The following is a description of a gene set: from publication Yevshin I, Sharipov R, Kolmykov S, Kondrakhin Y, Kolpakov F (PMID 30445619) Human Gene Set: SETD1A_TARGET_GENES Genes containing one or more binding sites for (SETD1A) in their promoter regions (TSS -1000,+100 bp) as identified by GTRD version 20.06 ChIP-seq harmonization. studied in species Homo sapiens, and this is the list of marker genes: TTLL5, FNBP1, FANCM, CIDECP1 (CIDEC pseudogene 1), CUL9, SEPTIN7, ZNF148, SLC25A26, COPS7B, SNHG29, CDK1, NDUFAF1, GMFB, NDUFA9, NUMB, YY1AP1, NOP16, RBM12B-DT (RBM12B divergent transcript), SRPRA, TACO1, USP18, TCEANC2, JRK, PSMA3-AS1, C19orf48P, TOMM22 (NCBI Gene Id 56993), MRPS16, TIMM10, RNF213-AS1, MYBL1, BTRC, C9orf43, HEATR6, CNOT6, CIAO2A, TPR, AKAP3, SLC3A2, TOMM22-DT, TUT1, TMEM256, NUCB1-AS1, UQCC3, PLEKHA8, PPP1R8, RPL3, TMEM237, CMTR2, SGO1-AS1, FBXW7, NDUFS4, UCKL1, SRSF10, PRDM10-DT, ATF6-DT, ESPL1, RPL29, MRPS30-DT, KLHDC3, FAM187A, SEPTIN7P13, CBFB, MICU2, TMEM167B-DT, ZNF596, KPNA6, ATF7-NPFF, LARS1, NECAP1, CPD, NOM1, TENT5A, DNAL1, GTPBP10, NUDT9, SLMAP, PCYT1A (NCBI Gene Id 5130), RPL30, SH3BP5L, ZNF524, SSBP1, LACTB, ZNF225-AS1, TCERG1, ESYT1, FOXRED1, TMEM9B, PATL1-DT, TAF5, FANCD2, PTCD2, CCDC59, ENSG00000253986, TMEM59, ZFAT, RLF, H2AC5P, TIAL1, HMBS, TMCC2 (transmembrane and coiled-coil domain family 2), COA6, RMDN1, SDHB (succinate dehydrogenase complex iron sulfur subunit B), PEX19, SBF2, DPH1, COX7A2, YARS2, TMA16, OXCT1-AS1, TSPAN31, GTF2IP20, CCT7, IRF9, PNN, DUS3L, STRAP, KMT5B, CTR9, GBF1 (golgi brefeldin A resistant guanine nucleotide exchange factor 1), KIAA0753, ZBTB40, PPP4R3B-DT, TCEA1, ABHD12 (abhydrolase domain containing 12, lysophospholipase), ALG12, TPRKB, STX18, SART3, IMP3, UBE3B, COMMD1, SLC25A37, VPS13B, PCLAF, FAU, C2orf42, SEC23B, AP1AR-DT, SAP30BP, PPP1R37, NUPR2P1, LINC01881, EID3, PES1, SH2B1, MED26, ARHGAP1, LINC01089, PAXBP1-AS1, NAV2, SNRPB, RPS27A, CFAP418, ZNF383, C7orf50, NUDCD1, SYS1-DBNDD2, STAMBP, ZNF501 (NCBI Gene Id 7602), CSTF3-DT, HADHB, KIF18B-DT, RABGGTB, MRPL21, RALGAPA1, SNRPC, BUD31, MIR638 (NCBI Gene Id 693223), SRRD, KLHL7, COQ7, NUDC, NUP85, EMC7, LEMD2, USP15, MTERF4, DHODH, DHRS1, MCM8, ZNF341-AS1, BAD, ZNF787 (NCBI Gene Id 126208), RPS15, HARBI1, GTF2IP13, STX18-AS1, FAM177A1, BSCL2, TRMT1, ERVK3-1, DRG2, DNM2, SYS1, MRTFA, KIF18B, CSNK2A1, ZNF83, UBL3, COMMD3, RPS13, CISH, ANAPC5, TOE1, GPS1 (NCBI Gene Id 2873), DDRGK1, ANKRD54, MED18, CEP120, PPP1R12C, MRPS15, ZNF585B, DHX16, RSL24D1, FDPS, WARS2-AS1, TIPIN, DYNC1I2, SF3A3, BSDC1, ENPP4, SUCLG1, TPX2, GTF2H1, ANKRD40, ANKMY1, GRWD1, XRCC5 (NCBI Gene Id 7520), DERL2 (derlin 2), ZZZ3, MKLN1-AS, GOLGA3, HEATR6-DT, SLC25A44 (solute carrier family 25 member 44), ZNF384, LETMD1, MTCH1, RPS12, ANKRD17-DT, SCRN3, NSA2, NAGK, NDUFA7 (NADH:ubiquinone oxidoreductase subunit A7), PYCR3, KEL, CDC42BPA, NELFA, ZNF25-DT, TOM1L2 (target of myb1 like 2 membrane trafficking protein), USP14, FBXL18, ITFG2, RPL18, TRAK2, R3HCC1, MRPS31P5, RFNG, CTNNBL1, MIR5091, ITGB3BP, RERE, GGA1, RAB21, ZNF585A, ARL8B, LAS1L, HMGXB4, RPL27A, VGF, MIR6790, ATG13, OGFOD3, HASPIN, NUP133-DT, DAXX, PAFAH2, ZW10, SLC66A2, HACD3, GID8, SOX2-OT, EIF1AD, AMBRA1, BOD1, ESF1, NCDN, DSTYK, MRPS30, RTTN, TTC32, CCND3, ISY1-RAB43, PPP3CB, THOC1, CD101-AS1 (CD101 antisense RNA 1), PSKH1, SLC25A11, CYB5R4, WDR37, U2SURP, C11orf58, SNF8, PTK2B, SLC25A28, CCDC115, MRPL35, SVIL-AS1, CDK5, WDR70, KIF15, NAPG, SLC4A1AP, ZNF414, ANKHD1-EIF4EBP3, BORCS8-MEF2B, URM1, TARS1-DT, MARCHF2, STAG3L5P, PHB1, ENSG00000260592, ERGIC2, ARPC4, LTN1, MRPL39, SENP3, MAPKBP1, MPV17, REXO1, UTP15, METTL9, PSMC3, LAMTOR5, SPAG9, DIDO1, COMMD9, TBCB, CRYZL1, PCBP1-AS1, YTHDF2, MICB, SEPTIN7-DT, SKA3, ATP5F1A, ZNF598, DNAJB12, MCRS1, MRFAP1, WDR43, EXOSC6, PYM1, ALG9, MKLN1, SETD1B, ATP6V0D1-DT, LINC00656, NUBPL-DT, ALG5, ABT1, PARP2, CLASRP, ZNF646, ZNF668, SYNJ1, TMEM230, TSN, NMT1, PHF8, ARMT1, KLC4, PUS3, RN7SL75P, SNORD49B, GTF3C3, ATAD3A, ZNF131, ZNF565, KCTD10, RNF167, SLC35A5, SNRPF-DT, MRPL22, UBAP2, DCP1B, HEXIM1, KRT8P12, EXOSC5, MAP3K11, SLC25A32, HSPA13, AMDHD2, GPR108, ATXN7L2, SEPTIN7P2, LBH, ZC2HC1C, MPDU1, CDKL3, ZFX-AS1, WASF1, RPL22, EEF1B2, PPP2R3B, STAP2, SMIM14, MAF1, TECPR2, AAR2, MRPS33, SLX4IP, NDUFAF8, EFCAB7, NDUFS6, PGBD4, VCPIP1, C19orf47 (NCBI Gene Id 126526), RSAD1, LSM5, CLCN3, SLC35B1, HADHA, LINC02288, SMPD4, FAM234A, PMS2P3 (NCBI Gene Id 5387), PPP2R3C, MAZ, CA1, SNORD15A, DPCD, DHX30, LARS2, UNC50, GPR137, CRYZ, RMND1, ARID4A, ACTMAP (NCBI Gene Id 284325), CENPM, POLL, GAR1, PMEL, DDB2, SNRNP27, CLP1, MTMR9, HAVCR2, FAM98B, SMAD6, VPS13B-DT, NXT2, CRACD, DCP1A, NOP9, ZC3H13, SUV39H1, MRPL49, ANGEL2, GRIPAP1, SMG7, RPTOR, MZT2B, RPS3, ADPRS, BORCS8, ATP13A4, ZNF350, GFOD1, SMARCA5-AS1, RRP1B, IRAG1-AS1, COPS4, NOC2L, PSMD7-DT, CCDC18, PIN4, DRC3, SHKBP1, RBSN, CDC40, ENSG00000268129, FAM228B, LIPE-AS1, YTHDC1, ANXA2R, RNU7-27P, FUZ, LAMP1, COG4, PTGES2-AS1, RPN1, ANKHD1, KDM1A, PIGK, PATL1, NUP133, PCBP1, CCT8, PDAP1 (PDGFA associated protein 1), KLHDC10, C1D, ASB16-AS1, ITGAE, HIBADH (3-hydroxyisobutyrate dehydrogenase), DESI2, LMNB2, LRIG1, COA8, SNRPF, SDCBP2-AS1, PDE6D, CCDC97, SUPT4H1, TNK2-AS1, MED7, LMNB1-DT, ZNF586, RBBP5, TTBK1, FIZ1 (FLT3 interacting zinc finger 1), JPX, CDC27, BLOC1S6, CACTIN, GSTCD, NUCKS1, SCAMP1-AS1, GBA1, LONP1, THUMPD1, MIR4512, PNO1, MCMBP (minichromosome maintenance complex binding protein), RBM26-AS1 (RBM26 antisense RNA 1), TRMT6, INO80B-WBP1, MEA1, VPS33A, SUPT5H, MIR3124, BRWD3, UBE2I, CHMP4B, AK2, DNAJA2-DT, LIX1L-AS1 (NCBI Gene Id 105371260), CREB3L4, RPS7, ST13, SNRPA1, ARMC1, PUF60, ARHGEF7, RAB5B, MANBAL, RTF1, CPSF7, MRPL36, CHASERR, DCUN1D3, KATNA1, SF1, NFXL1, CDK13, ENSG00000282936, PABIR1, DENR, E2F4, TTF2, TOR1A (torsin family 1 member A), TRIM56, DCAKD, CAMTA1, GCN1, DLGAP4, KNL1, HAX1, FAM149B1, NDUFS1, LARP4, EEF1E1-BLOC1S5, TRIP4, HEXD, BLOC1S1, CCRL2, MRPL1, VRK1, CNOT7, ZBTB43, SBNO1-AS1, ABCB9, CHCHD2P1, RNA5SP146, CDHR3, PI4KB, POMP, SPTLC1 (serine palmitoyltransferase long chain base subunit 1), DTD1 (NCBI Gene Id 92675), AREL1, CDC14A, MFAP3L, ERCC1, GTF2IP12, TLN2, ANKRA2, CDK5RAP1, CYB5B, USF3, ODR4, TMEM183A, TMEM256-PLSCR3, CAMTA1-DT, ARID3B, MDH1, MT-RNR1, MDN1, SLC25A53, GAR1-DT, ERP44 (NCBI Gene Id 23071), SMIM14-DT, EIF4A1, PCBP2, CDC73, EEF1E1, ALG10, NUP205, PPP4R3A, E2F6, MED23, TARS1, CASC3, LRPPRC, ARHGAP11B-DT, MAP3K7, MTOR, LARP7, DZANK1, MRPL16, AP1AR, CHCHD5, GOT1, TTC23, ENSG00000275740, TIA1, RFX1, SIPA1L3, HSF2BP, OBI1, DOHH, RN7SKP114, IZUMO1, NUDCD3, ARPC4-TTLL3, MED9, NDUFC2-KCTD14, FCF1, SIRT2 (NCBI Gene Id 22933), ZSWIM3, ENDOV, SNX1, ANKRD13A, LRRC41, C10orf143, KIAA1143, POLR2J4, WDR76, WDR89, MPPE1, RPL17, TARDBP, SPHK2, MRPL44, DPH3 (diphthamide biosynthesis 3), ARL6IP5, MAPK14, HCG14, TMEM38A, POLR1G, ZNF408, NUP93-DT, CDCA5, POLR3D, TRIP10, EMG1, SBNO1, SNHG31, IDH3B, ARL2BP, MED27, COQ7-DT, NBAS, VPS37A, ATG7, ANKRD17, RPIA, GTF2IRD1P1, PEX14 (NCBI Gene Id 5195), SEC13, LTO1, ITK, SCAMP1 (secretory carrier membrane protein 1), ZNF267 (zinc finger protein 267), DEPDC5, HDAC6, SREK1IP1, RPS8, RPLP2, MED31, ARL5A, CLUAP1, BRPF1, MIR4521, PKNOX1, CCR5AS, SNORA13 (small nucleolar RNA, H/ACA box 13), ATXN1L, ZNF160, RABEP2, ERG28, ATG9A, CEP350, OTUB1, TAFA2, NCOA5, EEFSEC, SRSF3 (serine and arginine rich splicing factor 3), NLGN2, KARS1, RBM26, LINC01932 (long intergenic non-protein coding RNA 1932), DHX35-DT, TIMM9, CPB2-AS1, BANF1, SNORD101, DDX19A-DT, SLC15A4, INVS, MAPKAPK5, SRFBP1, BCL6, TMEM222, TAF8, COPS8, CDC123, UQCRC2, POLR2I, PAK1, UQCRH, FAAP100, CHCHD2, ETFBKMT, AP1G1 (NCBI Gene Id 164), ENSG00000261335, CENPU, RFXANK, SP7, YME1L1, PIGB, TRDMT1, SURF1, FAM133B, SPAG4, ITSN1, ARHGAP19, ACOX3, WEE2-AS1, SLC7A1, FEM1A, TTC32-DT, CCDC12 (coiled-coil domain containing 12), NFKBIB, SZRD1, ADD2, XPNPEP3, RTN4IP1, BNIP2, VPS50, NOP58, CDKAL1, SRCAP, PNPLA4, MTF2, RPL17-C18orf32, SCAF4, EXOSC8, DCTN6-DT, NDUFC1, SF3B6, IL23A, RFX5, ICAM5, NUBP1, MAD2L1BP, ZDHHC12, LBHD1, NCBP2AS2 (NCBP2 antisense 2 (head to head)), SLC18B1, H4C8, ZC3H10, SPRED2, NCAPD2, SLC39A7, GABPA, C2orf49, OGFOD2, AP5M1, TFAP2A, RAB2B, TSPAN4, UTP3, RBM12B, C2orf49-DT, HS1BP3, AP3B1, KMT2A, FAM114A2 (family with sequence similarity 114 member A2), NIPA2, NDUFAB1, PRKRIP1, RAD51AP2, TIPRL, RPS10, TBCCD1, TRUB2, RPL7L1, CBR4, MIR4453HG, NFE2, IDH3B-DT, EPCIP-AS1 (NCBI Gene Id 54067), ATP8B1-AS1, ZNF510, SLC39A3, CEP162, BUD13-DT, CTSB, PAXBP1, VIRMA-DT, ZNF724, PLD3, WDPCP, EXOC5, DHPS, EWSR1, SMYD3, GUCD1, C9orf72, GOT1-DT, ALAD (NCBI Gene Id 210), NUP43, PRANCR, ALG1 (ALG1 chitobiosyldiphosphodolichol beta-mannosyltransferase), MIR320A (microRNA 320a), LAMTOR5-AS1, DUS2, CCDC174, VAMP3, RECQL5, UBE2B, BECN1, NLK, COPS8-DT, NDUFS7, CCT5, ANKRD18CP, POLR3A, KIAA1586, KBTBD7, MAP4K2, STRIP1, TM2D1, GANC, YJU2 (YJU2 splicing factor homolog), SF1-DT, NUBPL, MRPS28, HEATR1, NUP107, MRPL57, NUDT2, ATF6, RFX5-AS1, GTF2F1, ANKHD1-DT, WDR83OS, TMEM167A, ZNF451, INO80, IRAK4, LINS1, CLHC1, KDM5C, DNAJA2, TOX4, SNAPC2, EPB41L4A-AS1, SNRPG, FRG1, SSU72, CNPY2-AS1, MLST8, INO80B, ZCCHC7, UTP11, RBM28, ZNF718, C8orf33, TADA3, GGNBP2, CNOT2, CXXC1, QRSL1, RPL24, GPBP1L1 (NCBI Gene Id 60313), EIF2S3, MASTL, HPS4, TMEM198B (transmembrane protein 198B (pseudogene)), KIAA2013, SUPV3L1, TMEM39A, NUP54, MIR130AHG, CETN4P, ZNF564, KAT5, PSCA, TXNRD2, PRORP, ZNHIT6, C1orf159, KLHL22, ZGRF1, DHX32, AKAP8L, MICOS13, POLE3, MRPL2, ALG10B, CNOT1, TMEM242-DT, MFAP3, AQR, STRADB, PNPT1, ZNF736, HMOX1, HDAC1, WDR75, SLC30A6-DT, DARS1, ACBD5, CBR4-DT, PNISR, NUP107-DT, ACYP1, SLC25A28-DT, UBE2J2, PEAK1, TAF1A-AS1, CIPC, CSTF3 (cleavage stimulation factor subunit 3), TRMT5, SMIM7, PSMD11, FANK1, LYRM1, PFDN4, DNAJB11, KDM5A, NMNAT1, NUP58, PRPF40A, PSMD13, ZBTB3, SLC4A2, TIMM44, NHLRC2 (NCBI Gene Id 54835), AHSP, PTGS1, CATSPERD, PRCC, ZFP36L1, CAST, PPP4R3B, PSMD3, ZNF689, RABAC1, POLR2L, FAM216A, SEPTIN7P14, ANKZF1, TSPO2, RAP2A, SLIRP, TAMM41, ZBTB37, ELAC2 (NCBI Gene Id 60528), MRPL58, ISY1, PSME3, PTGES2, HDGF, PPIL4, RBM8A, SNORD55, ZNHIT1, RFT1, SRSF11, HCFC2, ENY2, WARS2, COPS7A, RIOK2, CCNT2 (NCBI Gene Id 905), SECISBP2, RMC1, S100A4, GCA, TMED2, TNPO2, TMED10 (NCBI Gene Id 10972), DNAJC11, RXRB, RPL22L1, C5orf34, CARINH, E2F2 (NCBI Gene Id 1870), MRPL51, RPL7 (ribosomal protein L7), SDF2L1, S100PBP, ZNF226, PLOD3 (NCBI Gene Id 8985), FARS2, ENPP3, GFM2, LANCL2, METTL2B, ANO10, HEMGN, KYAT1, PEX26, ATXN7L1, TAF1A, CCAR1, IPPK, ERCC5, SDHAF2, ZSWIM4, PPP1R13L, AASDH, BCKDHA, GAS8, ZFAND1, CS, POLDIP2, MICU1, TOR1AIP1, SUPT16H, RPL36, KAT6B, SETD1A, C12orf43, COX16, TRIR, TMEM9B-AS1, SLC35E1, CERT1, TMEM41B, EFCAB14, BBS9, BAG5, CLPB (ClpB family mitochondrial disaggregase), MSL2, PIGBOS1, BBS12, PLAA, UBR4, AFG3L1P, DCLRE1A, HMG20A, CAP1, DCAF13, CUEDC2, RPL21, SBF2-AS1, COA6-AS1, GLT8D2, LYRM4, CCDC107, SMG7-AS1, TBRG4, TIMM21, DSN1 (NCBI Gene Id 79980, DSN1 component of MIS12 kinetochore complex), RCE1, ABHD13, MRPS27, POM121, NAA15, PHB2, RHBDD3, TMEM126B, MAPKAPK3, MORF4L1, TMEM167B, USP16, RMRP, RANBP1, E4F1, CIR1, GNRHR2, PPP2R5C, RPL23AP53, RDH10, NOL6, RPS27AP3, BAZ2A, ZFYVE1, NUP155, TYW1, RPL26, ATR, C17orf100, DDX23, IMP4, SMIM26, PUM3, GPN3, H4C3, SURF2, MRPL28, COG2, DYNLT2, MIA3, PLRG1, DEDD, ITGA7, RAMAC, FAM135A, CYP46A1, MRPS35, VIRMA, RPS18, RPS28, ARHGAP19-SLIT1, CCAR2, NUCB1, RHOF, DHX35, ZNF331, TSR2, ZNF839, DCTN6, UBC, DDX1, FRG1HP, MKKS, STAM-DT, HSPA9, SF3B3, HSD11B1L, TERF2, ZNF146, LYSMD1, RNASEH1, DNAJC19, FBXO15, RBM27, CSTF2T, WDR87, ERI2, TCHP (NCBI Gene Id 84260), KIAA0586, ENSG00000187951, GAS5, TEPSIN, YARS1, GNL3, SCNM1, HLTF-AS1, IKZF4, GFOD3P, TRMT44, MAPKAPK5-AS1, PSMC6, TEX30, PSMD9, VEZF1, ERI1, EVI5L, XPO6, TBL3, POLR2M, DNM1L, CSTF1, NUDT5, PHIP (pleckstrin homology domain interacting protein), FBXO5, RWDD1, CDC23, CWC27, SRP72, FOXJ3, INTS12, OXNAD1, EIF3F, FKBP3, NUP93, PBRM1, STK40, ANAPC7, FAM32A, PSMA3, UBR2, VDAC2, TMBIM1, ZNF225, STAG3L5P-PVRIG2P-PILRB, NDUFAF5, NCBP2, MTMR10, DNAJC30, LRRC40, RPS15A (ribosomal protein S15a), EEF1A1P23, HPS5, PUS7L, CLCN5, CCDC103, CENPL, FASTK, PSMB5, TMEM242, PRPF40B, COIL (coilin), SUSD6, PSMC4, DDX25, ATP5PF, MTLN, PRKAB2, LRRC28, OPA1, USP30, BOD1L1, NKIRAS2, PAN2, AKT2, NAGPA, MPDU1-AS1, TXNL1, HOMER2, SNRPA, INTS2, SNORD58B, ARID1A, RTCB, ZSWIM8, ATP6V0D1, ABHD16A, SFSWAP, TBC1D31, PDCL, ZNF518A, BTBD10, WDR83, SNORD46, FKBP14, CRELD2, CCDC77, SSR1, EFTUD2, MFSD14A (NCBI Gene Id 64645), NPW, RPL27, HS2ST1, ITFG2-AS1, VCPKMT, VPS4B, ARMH4 (NCBI Gene Id 145407), METTL25, SP2, DGKA (diacylglycerol kinase alpha), KAT8, STARD7, SNAPC5 (small nuclear RNA activating complex polypeptide 5), BUD13, TMEM14B, CINP, PHF23, NSRP1, PSMD1, ZFPL1, STAM, RNF141, DPP9, MED30, MED6, PPIL1, HDGFL2, SART1, FRG1-DT, TSFM, LINC02926, ECSIT, ZNF324B, NECAP2, POLK, ATF7, ELOB, CDK5RAP2, C18orf21, COG5, KPNA5, POLR2K, BNIP1, SETDB1, THOC1-DT, UBXN1, NDUFS2, NRAS, ATPSCKMT, IFT74, TMBIM4, GCDH, TMEM41A, TRMT61B, PHF14, SNHG3, DNAJC14 (NCBI Gene Id 85406), ZDHHC12-DT, LMBR1 (limb development membrane protein 1), PPP5D1P, RPL41, SNRPB2, TXNDC17, TRMT2A, SPAG7, SIRT3, SGO1, KLHL7-DT, KCTD5, VPS35L, MRPL4 (mitochondrial ribosomal protein L4), TMEM245, NOLC1, PARS2, SGF29, RPL37, DNAAF10, TERF2IP (TERF2 interacting protein), HELZ, ENSG00000260830, MCL1, ATG3, PITHD1, TGIF1, HNRNPF, ZNF790, LINC00680, LSG1, ABRAXAS2, PISD, C10orf95-AS1, TMEM69, DDX41, PEX11B, MMADHC, FAM124B, SHARPIN, SNORD45C, E2F8, TMEM199, TIMM22, VPS52, FLAD1, SNRPD3, NFX1, RBM25, KAT6A, CUL2, CWF19L1, NDUFC2, TRIM35, ATG5, ZNF219, DDA1, DDX19A, COMMD3-BMI1, ALKBH1, SSB, BAX, G6PD, RSRC2, BORCS7, EPS8, IWS1, BORCS7-ASMT, ZNF302, MRPS35-DT, ZNF507, TUBGCP6, ADHFE1, DCAF1, TOMM6, ZNF25, LINC03100, ZSCAN12, FNBP1P1, ARL6IP6, RAB27A, SMIM13, SNORA73A, LZIC, PCNX3, MED24, SNRPA1-DT, E2F3, CCT4, SMARCD2, POLR3F, KIAA0319L, XRCC4, CHD8, AURKA, SMC2, CLPX, SLC38A6, SELENOF, COX17, COQ4, CCNT2-AS1, ZNF251, GPAM, EMC1-AS1, TRIP11, ERMARD, RANBP6, SUPT7L, KLHL18, MRFAP1L1, AURKAIP1, TRIM62, POLR2J3, PPP3CB-AS1, AARSD1, MUTYH, CIAO2B, RANGAP1, SCAF1, LMNB1, MAN2C1, EED, GLE1, HELB, TNPO1, LEISA1, MIX23, CALM3, IKBKG, RPS16, ZMYM2, COA5, IP6K2 (inositol hexakisphosphate kinase 2), PSMD7 (proteasome 26S subunit, non-ATPase 7), MTIF3, KDM4A-AS1, DNLZ, METTL3, SLC30A6, ACOT8 (NCBI Gene Id 10005), TMEM87A, KIF16B, RNF220, SNORD58A, TYW3, MRPS23, IMPACT, ECD, FAM50B, SLC25A3, IFIH1 (NCBI Gene Id 64135), RBM42, DNAJC7, PIDD1, DDX50, SPPL2A, TBL1X, KRR1, GART, SAR1B, PIP4K2B, FARSA, TMEM128, KIF9, FAM162A, MSANTD4, RAD52, MIS12, ARMC8, DUS4L, LRRC8A, IGHMBP2, MTO1, TMUB2, RUNX1T1, MT-TF, MED15, BUD23, FASTKD1, UXT, ACTR10, DLG2, DAP3, IST1, MRPL48, CES2, RNASEH1-DT, GEMIN5, TUFM, TMEM160, NR1H2, LIG4, SSU72-AS1, CENPBD1P, MRPS10, DNAI4, MIR1302-3, YPEL4, SLC25A17, RPP30 (NCBI Gene Id 283012)